The following is a description of a gene set: studied in species Mus musculus Genes negatively differentially expressed in cell type: cDC2 (conventional dendritic cell type 2) upon treatment with cytokine: Noggin in mouse lymph nodes in vivo. Cytokines mediate cell-cell communication in the immune system and represent important therapeutic targets. A myriad of studies have highlighted their central role in immune function, yet we lack a global view of the cellular responses of each immune cell type to each cytokine. To address this gap, the authors created the Immune Dictionary, a compendium of single-cell transcriptomic profiles of more than 17 immune cell types in response to each of 86 cytokines (>1,400 cytokine-cell type combinations) in mouse lymph nodes in vivo. A cytokine-centric view of the dictionary revealed that most cytokines induce highly cell-type-specific responses. For example, the inflammatory cytokine interleukin-1β induces distinct gene programmes in almost every cell type. A cell-type-centric view of the dictionary identified more than 66 cytokine-driven cellular polarization states across immune cell types, including previously uncharacterized states such as an interleukin-18-induced polyfunctional natural killer cell state. from publication Cui A, Huang T, Li S, Ma A, Pérez JL, Sander C, Keskin DB, Wu CJ, Fraenkel E, Hacohen N (PMID 38057668) Mouse Gene Set: CUI_CDC2_NOGGIN_RESPONSE_DN, and this is the list of marker genes: Dusp1, Pmaip1, Atf3, Junb, Klf2, Zfp36, Fos, Il1b